The following is a description of a gene set: part of: Hyaluronan metabolism Hyaluronan (HA) turnover can occur locally at the tissue of origin, where it is taken up by cells to be degraded, or released into the lymphatic and vascular systems, where it can be eliminated by the liver and kidneys. Uptake of HA into cells for degradation involves receptor-mediated processes. Once HA enters lysosomes, the acidic conditions favour hyaluronidases to cleave it into small oligosaccharides, the most common size being a tetrasaccharide. Beta-glucuronidases participate in degrading the small oligosaccharides in the lysosome. Ultimately, HA is degraded into its constituent sugars (glucuronic acid and N-acetylglucosamine) which can be used to reform many glycosaminoglycans (GAGs) when released from the lysosome.<br>A third of the total HA content in humans is turned over daily and it has a short half life of minutes in circulation up to days in many tissues. The reasons why the body eliminates HA so rapidly are unknown but one possible explanation could be HA's role as a reactive oxygen species (ROS) scavenger. Removing these toxic compounds could explain the rapid elimination of HA.<br><br>There are seven different hyaluronidases (HAases) in humans: HYAL1, HYAL2, HYAL3, SPAM1, and CEMIP. Reactome Pathway: Hyaluronan degradation studied in species Homo sapiens, and this is the list of marker genes: HEXB, SLC9A1, HEXA, CD44, HYAL1, GUSB, CEMIP, HYAL3, STAB2, HYAL4, LYVE1, HYAL2, SPAM1, SLC17A5, HMMR, CHP1